The following is a description of a gene set: Genes with promoters bound by PPARG at 8 day time point of adipocyte differentiation of 3T3-L1 cells (preadipocyte). species: Mus musculus Control of cell differentiation occurs through transcriptional mechanisms and through epigenetic modification. Using a chromatin immunoprecipitation-on-chip approach, we performed a genome-wide search for target genes of peroxisome proliferator-activated receptor gamma (PPAR gamma) and its partner protein retinoid X receptor alpha during adipogenesis. We show that these two receptors target several genes that encode histone lysine methyltransferase SET domain proteins. The histone H4 Lys 20 (H4K20) monomethyltransferase PR-Set7/Setd8 gene is upregulated by PPAR gamma during adipogenesis, and the knockdown of PR-Set7/Setd8 suppressed adipogenesis. Intriguingly, monomethylated H4K20 (H4K20me1) levels are robustly increased toward the end of differentiation. PR-Set7/Setd8 positively regulates the expression of PPAR gamma and its targets through H4K20 monomethylation. Furthermore, the activation of PPAR gamma transcriptional activity leads to the induction of H4K20me1 modification of PPAR gamma and its targets and thereby promotes adipogenesis. We also show that PPAR gamma targets PPAR gamma2 and promotes its gene expression through H4K20 monomethylation. Our results connect transcriptional regulation and epigenetic chromatin modulation through H4K20 monomethylation during adipogenesis through a feedback loop. Human Gene Set: WAKABAYASHI_ADIPOGENESIS_PPARG_BOUND_8D from publication Wakabayashi K, Okamura M, Tsutsumi S, Nishikawa NS, Tanaka T, Sakakibara I, Kitakami J, Ihara S, Hashimoto Y, Hamakubo T, Kodama T, Aburatani H, Sakai J (PMID 19414603), and this is the list of marker genes: MEGF9, DICER1, AGO1, ZNF2, ITIH4, NDUFAB1, LZIC, ST3GAL4, PLSCR1, ACACA, HIPK2, YWHAH, SLC27A1, EIF2S1, GRB2, ZBTB40, RMDN2, TRIM23, CELA1, ZNF93, SEMA6D, ROCK2, CTH, MEF2D (myocyte enhancer factor 2D), NPR3, KEAP1, MOCS1, GSTT2, PHF12, LPIN2, STARD7, KRT4, LPXN, DCK (NCBI Gene Id 1633), METTL17 (NCBI Gene Id 64745), GSK3B, ABCD1, GLCCI1, MMP11, IK, CD1D (CD1d molecule), ELL, EBF1, PRR14, IGFBP7, TMEM176B, TGFB1I1, H4C1, TFB1M, RABGAP1L, RPRML, PRKCE, BIVM, USP48, ADAM9, ADD3, PIGM, FAM83F, ATE1 (arginyltransferase 1), CYB5R3, PPME1, TOP2A, PLIN4, C2CD3, MBD4, AHNAK, MTPAP, MLLT10, CITED2, SIN3A, IFT122, ATL2, C1QTNF12, ARHGEF40, MEIS2, FBXL6, TMEM98, PDK4, RBM14, MRI1, ARHGEF12 (NCBI Gene Id 55406), LGI4, MET, THPO, INSR, BID, LRCH3, TK1, JAK3, UQCRQ, VMP1, RORC, INPP5F, OXSM, RWDD3, SPTBN1, BABAM2, ZFP91, RB1, ARPC5, HCLS1, ZFP36L2, BCAP31, IL6ST (NCBI Gene Id 3572), HES7, DNAJC16, N4BP2L1, DECR1, USP15, C1QTNF2, CIAPIN1, CFAP36, GRHPR, MTOR, PRKCA, SLC52A2, TMIGD1, FNBP1L, CRADD, RFXAP, SPAG9, LOXL2, FBXW11, CHCHD6, SPSB1, DGCR8, BAG2, NFE2L2, CPT2, IBTK, FANCC, NCOR1, PTGES, MB, AFMID, TLE3, SPRY4, IKZF1, TOB1, BRCA1, EGR1, LMLN, WDR6, ZNF24, CENPB, KIF5C, EPN3, RNPC3, CERS2, ARHGEF7, KLKB1, EI24, GNAS-AS1, AZI2, MIB1, FKBP10, BCORL1 (BCL6 corepressor like 1), ZBTB2, GPR182, ACOT13, RCL1, LPCAT3, SCRT1, EAF2, IRX5, CHRD (NCBI Gene Id 96177), FBH1, KRT19, AKTIP, IQCC, LGALS3, ZNF7, FOSL2, PRKAR1A, ZNF423, PPP2R5D, PLA2G12A, UCP3, DLD, KDM7A, ATOSB, PIAS4, CD164, ACP2, GSDME, RNF8, ZRSR2, CPE, FZD8, ZZEF1, MYNN, DCTN2, SERPINB9, FBXW4, PRELID2, ERLIN2, LRRC28, OSBPL3, RUVBL2 (RuvB like AAA ATPase 2), UNC45A, ALS2CL, ACSL1, XPA, SDE2, GDF9, SLC44A3, IFT81, THOC1, RDH16, INVS, FBXW5, EHMT1, KANK1, ABCF1, DHX35, SEC63, MAPKAPK5, KRI1, ACTA1, KLK10, PKMYT1, MYC, OPTN, ABHD2, DNAJC5, HSPA9, ZNF672, FOXP1, PLK1, PLXDC1, NUMBL, CTPS2, SOX4 (SRY-box transcription factor 4), CAPRIN1, APTX, PCGF5, POLK, NELFCD, BHLHE41, RASL11B, DCUN1D4, MGRN1, LNX2, COQ9, RUNX2, SP3, POLR1D, SPHK2, FKBP7, RIMOC1, TPD52L3, ZNF670, PCCB (propionyl-CoA carboxylase subunit beta), FRMD5, WLS, ZNF408, LIX1, MTMR4, B3GAT3, TRIM41, SPATA3, CLPP, AZIN2, SOS1, ADRB3, GYS1, CCM2, GNA13, SETD4, MAST2, ARHGEF2, CCDC141, ARSB, FSD2, NDUFA2, SOD1, BRI3BP, CDCA7, WNK4, EMG1, SAP30, PPP4R3B (protein phosphatase 4 regulatory subunit 3B), DHRS11, MPDU1, LIMS1, DLX5, AIP, EYA1, CALR3, HDDC3, ZNF574, ZNF444, CCNI, ST3GAL6, ACTRT3, VCP, BOC, SCAF4, PLCG1, FBF1, FAF1, BAAT (NCBI Gene Id 570), ZNF124, GTF2I, SLC5A3, FGD6, ME1, ARHGDIB, KRT14, PER1, GNAZ, GLB1, ASPN, ZBTB21, CDK14, ARL6IP6, TMEM39A, HPRT1, SPEG, PRKAR2B, EZH2, PRUNE1, DGCR2, IRF4, PTRH2, RARS2, OAS1 (NCBI Gene Id 4938), ARHGEF10, PTS, SUPT3H, SPSB2, PRKAG2, HINT3, VEGFA, PRPF18, CHSY1, CHD1, KLF10, SGO2 (NCBI Gene Id 151246), GBP4, IGFBP1, G6PC1, NDUFB2, HOPX, DIDO1, ZHX3, CAB39L, ABR, PALMD, EIF2AK4 (NCBI Gene Id 440275), POLR2G, HSPE1, CHCHD4, GSTM2, PALM, GNPAT, AKAP1, CAMK2D, WDR41, IFT140, RBM39, DNAJA2, GEMIN4, TMEM109, CUEDC1 (CUE domain containing 1), CCL15, LURAP1L (leucine rich adaptor protein 1 like), GNAQ, TMIE, HSPD1, KLHL7, RWDD4, CLPX, DIXDC1, MAP2K1, RBAK, ACSM5, IHH, BCAS3, ABLIM1 (NCBI Gene Id 3983), USP14, RPIA, IL6R, SPEF1 (sperm flagellar 1), RBM48, JADE2, CRELD1, NAGK, FAIM, ACTN4, PRPF38B, OAF (out at first homolog), ATXN7L2, CALM1, HADHA, POLR1H, SAFB2, TIMELESS, ZBTB7B, CHST6, ALDH9A1, TMEM43, PHLDA3, CBX8, PUS1, GALNT4, WWTR1, HSD17B10, TMEM69, PEBP1, YIPF3, CES1, RPA3, HCAR2, CDADC1, DHRS7, GBP2, IQCB1, DUT, ERI2, ERP44, ANGPTL1, PICALM, UBAP2, ARHGEF6, UACA, UBAP1, MDFIC, SLC3A2, DYSF, F3, PSMF1, ELMO2, GMFB, GYPC, RAD51D, PLXNA1, CILK1, SGMS1, ATP6V1A, SPON2, TMEM176A, TTC7A, RAB11FIP4, ALDH2, TSPO, MARK2 (microtubule affinity regulating kinase 2), DENND2D (DENN domain containing 2D), SDCCAG8, MXD4 (NCBI Gene Id 10608), ENO1, CHAD, CDH13, ST3GAL3, TRIM69, MTERF4, AK3, WWP2, TSSK2, CHIT1, TMEM126B, PAFAH1B1, AFAP1L2, DUS3L, ALAS1, HELB, CSRNP2, CBR1, PNPLA7, MRPS5, UBIAD1 (NCBI Gene Id 7801), CLN5, FADS1, ATP6V1D, TMEM38B, RNF125, PEMT, PRPF40A, ARHGAP18, GSG1, HSPA8, ORC3, ARHGAP1, OSBPL9, ARSA, TRAPPC11, TTC19, NHEJ1, ANKRD17, RARA, FBXO9, EMC4, HEXIM2, SIK2, THAP3, FHL3, DEPTOR, KNTC1, GRTP1, GSTM1, MOV10, TMEM201, CXCL9, DISP2, AK2, PURB, G0S2, CTU1, TTC23, TSSK1B, AK1, ISOC1, OSBPL2, CEND1, LENG1, UBE2W, TRIM25 (NCBI Gene Id 7706), CASP9, BIRC6, GBP6, RTEL1, MRPL41, SETDB1, PPP1R37, ODAD4, ANGPT1, GRAMD1A, SPARCL1, LRRC8A, ALDH1A1, COMMD5, PGAM1, SUV39H1, MIB2, NAGPA, AIRN (antisense of IGF2R non-protein coding RNA), EIF6, SEPTIN9, APOBR, SPIN4, NAV1, POC1B, TRABD, ITGA7, ADAMTS15, BLCAP, PRPS1, CYB5D2, MAB21L2, CRLS1, MRPS6, SHISA5, NUDT21, ITGA5, ESCO2, NR4A3, EDF1, APONP, NUMB, TSPAN14, DLAT, DCBLD2, CEP250, NDUFB10, ACSF2, ITPKA, PI4K2A, KRT13, ING4, RBL1, IRX3, LYSMD3, CORO1B, CHST1, WDR35, SYAP1, RAD51B, CYLD, ERO1A, NUMA1, LY6G6C, MED11, KRT79, CPSF7, TRAF4, ZBTB3, AKIRIN2, EEF1A2, PAXX, EPB41L1, ACLY, RSRC2 (arginine and serine rich coiled-coil 2), UBB, TMBIM6, LPIN1, WDR82, EML4, HOXA9, IKZF2, IRS3P, TM2D2, PWWP3A, AACS, HADHB, AP3D1, UQCRFS1, ANXA8L1, HSD17B4, STK11, ARL6, TNFAIP3, DCTN4, TOP1, NOL6, PGM1, KLB, GALNT7 (NCBI Gene Id 51809), TMEM135, DUSP22, NINJ1, PRKRIP1, RMND1, ATP5ME, CHST8, FADS3, SHPRH, HCAR1, PHB2, FKBP14, ITGA1, BRD2, PLIN2, GSTM5, MKKS, RBKS, GNAS, CCDC77, TXNRD1, CALML3, DNAJB6, DYRK1A, TUSC2, KRT15, LGALS9